Given this list of marker genes COMMD1, ADIPOQ, APOA2, APOC3, LAMTOR1, here is a description of the gene set: species: Homo sapiens Human Gene Set: GOBP_REGULATION_OF_CHOLESTEROL_IMPORT Any process that modulates the rate, frequency or extent of cholesterol import. Cholesterol import is the directed movement of cholesterol into a cell or organelle.